Given this list of marker genes Slc30a3, Anxa6, Stard3nl, Pld1, Anxa8, Abca5, Lamtor3, Rmc1, H2-Aa, Chmp1a, Marchf8, Rilp, Arl8a, Chmp6, Anxa2, Snf8, Vps4b, Tspan15, Mvb12a, Clcn4 (NCBI Gene Id 12727), H2-Ob, Cd300lg, Atp13a4, Chmp4c, Chmp7, Slc30a4, Tpcn2, Lamtor1, Stard3, Lamtor4, Notch1, Stoml1, Lamp1, Ap5m1, Rab27a, Pmel, Galntl5, Vps18, Gimap5, Clcn6, Atp9a, Pld3, H2-Ab1, Pip4p1, Snx14, Mcoln1, Snx16, Tmem163 (transmembrane protein 163), Cdip1, Atg9a, Vti1a, Lamtor5, Yipf1, Slc31a2, Slc29a3, B2m, Atp13a2, Laptm4b (NCBI Gene Id 68111), Ifitm2, Arl8b, Mmd, Rhob, Slc11a1, Atp10b, Mreg, Cd68 (CD68 antigen), H2-DMb2, Mtmr4 (myotubularin related protein 4), Slc9a9, Mcoln3, Abcb6, Hgs, Rnf13, Tmem30a, Vps33b, Npc1, Plekhm1, Vps37c, Atp13a5, Chmp4b, Vopp1, Spaar, Sorl1, Mr1, H2-Eb2, Nsg1 (neuron specific gene family member 1), Litaf, Irgm1, Chmp3, Vps36, Ubxn6, H2-Eb1, Slc1a1, Slc38a9, Chmp1b2, Chmp1b, Litafd, Rab7, Osbpl9, Elapor1, Yipf2, Sppl2a, Vps28, Pikfyve, Vps37a, Abhd6, Baiap3, Zmpste24, Slc9a6, Lamp5, Pip4p2, Cd63 (CD63 antigen), Lamp2, Wdr91, Abca3, Chmp2b, H2-Oa, Slc31a1 (solute carrier family 31, member 1), Vps41, Stx8, Ifitm3, Nsg2, Vps11 (VPS11, CORVET/HOPS core subunit), Tsg101, Vamp8, Lamtor2, Chmp2a (NCBI Gene Id 68953), Tmem106b, Entrep1, Slc9a8, Cyb561a3, Vps37d, Chmp5, Wdr81, Vps16, Laptm4a, Vti1b, Vps39, Ntrk1 (NCBI Gene Id 97088), Vps13c, Rab27b, Vps37b, Osbpl11, Ap5s1 (adaptor-related protein 5 complex, sigma 1 subunit), Vps33a, Slc39a14, Cln3, Tmem59, H2-DMa, Atp13a3, Mapkap1, Mvb12b, Slc11a2, Stx7, Mitd1, Gosr2, Clcn3, H2-Ea, Micall1, Tmem9, Lamp3, H2-DMb1, Vps4a, Marchf1, here is a description of the gene set: Mouse Gene Set: GOCC_LATE_ENDOSOME_MEMBRANE The lipid bilayer surrounding a late endosome. species: Mus musculus